Given this list of marker genes USP53, USP17L10, USP34, USP17L11, TANK, MINDY4B, COPS2, USP10, USP11, COPS3, UCHL1, USP15, SENP5, USP17L6P, USP17L15, USP17L1, USP17L8, KDF1, USP17L20, OTUB1, USP40, USP28, USP13, USP36, OTUD1, CYLD, MINDY3, USP17L23 (NCBI Gene Id 101241878), USP9Y, USP17L12, USP20, ATXN3L, DNAJB2, USP17L2, OTUB2, USP21, VCP, COPS8, DESI1, OTULINL, USP24, USP17L19, PSMD14, USP49, USPL1, USP33, OTUD5, USP31, USP19, SENP1, OTUD3, ATXN3, USP17L5, ZRANB1, USP2, OTUD6B, USP5, USP17L7, USP17L21, USP48 (ubiquitin specific peptidase 48), NOP53, MINDY4, COPS7B, COPS7A, UBXN1, USP1, USP47, CDK1, USP6, USP17L22, USP4, USP17L13, COPS4, TNFAIP3, COPS6, PRKN, ZC3H12A, USP17L3, UCHL5, SENP8, USP27X, ABRAXAS2, USP26, OTUD7B, UCHL3, USP22, STAMBPL1, BABAM2, USP44, TRIM21, SENP6, USP25, USP46, USP35, JOSD2, USP17L24, USP45, USP43, USP51, USP3, SPATA2, HINT1 (NCBI Gene Id 3094), BAP1, USP16, GPS1, STAMBP, OTUD6A, COPS5, PARK7, BRCC3, SENP7, USP8, USP37, YOD1, SENP3, USP17L4, USP9X, SHMT2, ITCH, USP54, OTUD4, USP7, USP39, JOSD1, USP30, USP32, USP14, OTUD7A, TOR1A, USP42, USP29, USP38, SENP2, TNIP1 (TNFAIP3 interacting protein 1), USP17L17, VCPIP1, USP12, USP18, OTULIN, USP17L18, USP50, here is a description of the gene set: Human Gene Set: GOBP_PROTEIN_MODIFICATION_BY_SMALL_PROTEIN_REMOVAL A protein modification process in which one or more covalently attached groups of a small protein, such as ubiquitin or a ubiquitin-like protein, are removed from a target protein. studied in species Homo sapiens